The following is a description of a gene set: Genes predicted to be targets of miRBase v22 microRNA mmu_miR_3078_3p in miRDB v6.0 with MirTarget v4 prediction scores > 80 (high confidence targets). studied in species Mus musculus Mouse Gene Set: MIR_3078_3P from publication Chen Y, Wang X (PMID 31504780), and this is the list of marker genes: Chat, Adsl, Rufy2, Rft1, Carmil1, Tmtc1, Cpne9, Milr1 (mast cell immunoglobulin like receptor 1), Mfsd4b5, Snrnp25, Zfp408, Fbxo41, Cyp2e1, Rhbdl3, Tlcd2, Xpo7, Nfatc4, Cenpi, Padi4, Chst3, Sun2, Cnga3, Klhl18, Taf7l, Gpatch2l, Ghdc, Glod4, Pus7, Stard8, Malt1, Triqk, Stxbp5, Lrrc20, Rspo1, Fam117b, Zkscan2, Cnr2, Tnfsf14 (tumor necrosis factor (ligand) superfamily, member 14), Grk6, Zfp609, Zdhhc3, Lrrc2, Ago1, Mpv17, Tnrc6b (trinucleotide repeat containing 6b), Zfp935, Cacna1e, Mfsd11, Rnf139, Nlrp12, Cdk19, Nvl, Ptcra, Dele1, Efr3b, Myo1c, Sp5, Os9, Csnk1g3, Kat14, Gla, Ogdh, Fbxo11, Dcaf17, Zyg11b, Rbbp4, Cfap300, Kmt2a, Slc7a8, Rcbtb2, Aoc3, Robo3, Fgf1, Lyrm9, Wbp4, Timm8a2, Lifr, Moap1, Rtn4rl1, Ybx1, Otud5, Atrn, Creg1, Jmjd4, Pola2, Prc1, Lgr4, Ceacam2, Parva, Nupr1, Castor2, Frmd5, Spaca7b (sperm acrosome associated 7B), Bicral, Nup98, Rhov, Ceacam1, Pip4k2a (NCBI Gene Id 99429), Crtc3, Cxcr2, Zfp605, Phf19 (PHD finger protein 19), She, Nav2, Nfe2l1, Mrpl41, Yeats2, Urb2, Rtf1, Rps6kb1, Acod1, Gm10778, Mtfmt, Ndst2, Cd96, Gm20604, Coa8, Comt, Siglecf, Stxbp2, Mboat7, Dennd5b, Slc6a6, Rasl10b, H2-D1, Stxbp5l, Cdkl4, Nif3l1, Aak1, Decr2, Mprip, Ago4, Fbxo17, Tbc1d24, Hmg20a, Pip5k1c, 4931406C07Rik, Nmnat2, 2610028H24Rik, Ophn1, Rint1, Rab11fip1, Pcsk1n, Vps26b, Efna5, Arl16, Slc11a1, Dync2i2, Trp53rkb, Ska3, Pacs1, Rnf168 (ring finger protein 168), Pbx1, Med1, Pde10a, Slc43a2, Pcdh20, Pakap, Haus2, Spmap2l, Shisa7, Rp1, Ankle2, Nmrk1, Naa25, Col3a1, Hpgds, Kcng1, Pbld1, Tapbpl, Rabggta, Dmwd, Actg1, Lratd2, Ncam1, Klhl31, Eef1b2, Reep6, Oxsr1, Prf1, H2-T23, Scrt1, Plagl1, Tpra1, Tmem106b, Uba1, Syndig1, Il22ra2, Pcsk2, Ankfy1, Invs, Gon7, Naip5, C1rl (NCBI Gene Id 232371), Foxr1, Pogz, Dek, Irf9, Lysmd4, Ntrk2, Mfsd2b, Cenpq, Zfp607a, Pan3, Pdzd2, Churc1, Ttf1, Irak1, Mxd1, Mau2, Hip1, Soat2, Ptprb, Rfxank, Snx30, Trpc5, Gltp, Aifm3, Elf2, Eeig1, Irgm1, Doc2b, Bcas2, Kcnd1, Slc17a5, Mrpl51, Nom1, Oog2, Vezf1, Als2cl, Cntn2, Pde4c